The following is a description of a gene set: Reactome Pathway: Translesion synthesis by POLK This event has been computationally inferred from an event that has been demonstrated in another species.<p>The inference is based on the homology mapping from PANTHER. Briefly, reactions for which all involved PhysicalEntities (in input, output and catalyst) have a mapped orthologue/paralogue (for complexes at least 75% of components must have a mapping) are inferred to the other species. electronically inferred by orthology from the curated human pathway part of: Translesion synthesis by Y family DNA polymerases bypasses lesions on DNA template species: Mus musculus, and this is the list of marker genes: Rpa1, Rps27a (NCBI Gene Id 78294), Rfc3, Pcna, Rfc1, Polk, Rev3l, Ubb, Mad2l2